The following is a description of a gene set: The process in which a relatively unspecialized cell acquires the specialized features of a glutamatergic neuron. Mouse Gene Set: GOBP_GLUTAMATERGIC_NEURON_DIFFERENTIATION studied in species Mus musculus, and this is the list of marker genes: Irx6, Zhx2, Nrxn1, Rho, Pax6, Gnat2, Ikzf1, Bhlhe22, Mtpn, Atp2b2, Bbs10, Grid2, Naglu, Cbln1, Wnt7a, Prdm1, Irx5, Vsx1 (visual system homeobox 1), Ophn1, Cntnap2, Vsx2, Nfix, Kndc1, Cabp4, Lbx1, Casz1, Ndp, Prox1, Ulk1